Given this list of marker genes IGLJ3, MRPL49, CCR6, ERMP1, RPS14, RPLP0, GAS5, RHOH, IGKV1D-13, TSPYL2, CA6, NOP2, ZSCAN22, CPNE5, IGHD, NOC4L, BANK1, RALGPS2, CD79B, RPL3, ZNF85, USP44, CYB561A3, ABLIM1, TNFRSF17, VPREB3, UTP25, BTLA, SPON1, CD200, STAP1, IPO5, CD83, AFF3, FCRLA, ATF7IP2, HSP90AB1, ANKRD36BP2, USP21, WDR77, DANCR, AGMAT, FBXO5, PLPP5, APEX1, IGLV3-19, IGLL3P, SPDL1, UBE2D2, TLE1, TRAF5, TCL1A, FCRL5, ZBTB5, GRAP, CD19, PIK3C2B, NIBAN3, TMEM161A, IL7R, DKC1, SLC16A10, BDH1, FCER2 (NCBI Gene Id 2208), MS4A1, HADH, CD27, RPS3 (NCBI Gene Id 6188), RPL9, LDHB, SPIB, CXXC1, BACH2, MIR600HG, CENPH (NCBI Gene Id 64946), CENPV, CREB3L4, SLAMF1, CD247, GIMAP5, PMEPA1, SLC16A1, PLSCR3, CD22, P2RX5, MDS2, C10orf143, GEMIN4, ARHGEF18, SUSD3, RPS5, IGHV5-78, GCC2, EIF4E, PNOC, UTP20, LMAN1, MATN1-AS1, DENND5B, DPP4, JCHAIN, TXK, SNHG29, ALKBH2, PCDH9, DTX1, OCIAD2 (NCBI Gene Id 132299), HLA-DRB4, IVD, DDR1, SLC7A6, KLRB1, SCN3A, SOX8, TMEM220, GTF3A, PHB2, TNFRSF25, ETS1 (ETS proto-oncogene 1, transcription factor), CR2, CNKSR2, ARHGEF10, MZB1, CD48, ATP6V0E2, ICOS, LETMD1, EEIG1, KRT10-AS1, EIF3K (NCBI Gene Id 55373), BCL7A, IGHM, CXCR5, PTPRK, ABCB4, RPL21, RPS10P5, IGLV4-60, LINC00926 (NCBI Gene Id 283663), ID3, TSPAN13, RPS6, NELL2, QRSL1, OSBPL10, CD79A, HMCES, CDK4, OSTC, FCMR, PDE3B, COQ9, PFAS, USP11, HAUS5, FCRL1 (NCBI Gene Id 115350), IGLV1-44 (immunoglobulin lambda variable 1-44), MRNIP, IGKC, EIF3D, HVCN1, BLNK, KRT18 (keratin 18), EPHA1, CHMP7 (NCBI Gene Id 91782), DGKA, UQCC1, FCRL2, FAM30A, CORO2B, PRELID3B (PRELI domain containing 3B), PBX4, RPSA, GNPDA2, HAX1, DPH2, RTTN, EPM2A, HLA-DOB, IGKV4-1, PKIG, FLNB, POU2AF1 (NCBI Gene Id 5450), SEL1L3, SPTBN1, CD72, EIF4A2, TRAP1, CYP2U1, FARSB, here is a description of the gene set: Human Gene Set: GSE4984_UNTREATED_VS_GALECTIN1_TREATED_DC_DN studied in species Homo sapiens Human monocyte derived dendritic cells matured via galectin-1 or LPS. from publication Fulcher JA, Hashimi ST, Levroney EL, Pang M, Gurney KB, Baum LG, Lee B (PMID 16785517) Genes down-regulated in monocyte-derived dendritic cells: control versus treated with LGALS1.